Given this list of marker genes Tgfbr3 (NCBI Gene Id 73753), Fgf8, Ccn1, Mir18, Zbtb14, Lmo4, Dnah11, Bmp4, Nsd2, Dhrs3, Mir92-1, Zfpm2, Trip11, Notch1, Mir19b-1, Nphp3 (NCBI Gene Id 74025), Fzd1, Nos3, Pitx2, Cxcr4, Ift88, Chd7, Smad7, Hey1, Cited2, Tbx20, Mdm2, Mir20a, Kif7, Slit2, Pax8, Nfatc1, Parva, Nprl3, Sall4, Dand5, Heg1, Tbx2, Notch2, Hectd1, Matr3, Gata4, Msx2, Nog, Nrp1, Xirp2, Egln1, Rbm15, Wnt11, Mdm4, Smad6, Maml1, Pcsk5, Tgfbr2, Mir19a, Hand1, Dvl3, Tab1, Ap2b1, Wnt5a, Dnm2, Bmp7, Plxnd1, Cfc1, Kcnj8, Mir17, Sall1, Acvr1, Ank2 (ankyrin 2, brain), Vangl2, Bmp5 (bone morphogenetic protein 5), Fzd2, Prox1, Robo2, Aplnr, Tbx5, Nrp2, Sox11, Tbx3, Adamts19, Eng, Snx17, Robo1, Sox4, Id2, Stra6, Fgfr2, Mks1, Bmpr2, Lrp2, Lrp1, Gata3 (GATA binding protein 3), Bmpr1a, Sav1, Tgfbr1, Prdm1, Hey2, Fgfrl1, Gja5, Smad4, Lrp6, Ptk7, Cplane1, Slit3 (NCBI Gene Id 632373), Trp53, Frs2, Tbx1, Heyl, Fuz, Nkx2-5, Cntrl, Gata6, Hes1 (hes family bHLH transcription factor 1), Ltbp1, Sema3c, Ndst1, Isl1, Hoxa13, Zfpm1, Pde2a, Dctn5, Jag1, Adamts6, Smo, Luzp1, Tgfb2, Sufu (SUFU negative regulator of hedgehog signaling), Smarca4, Myh10, Rbpj, here is a description of the gene set: The progression of a cardiac septum over time, from its initial formation to the mature structure. Mouse Gene Set: GOBP_CARDIAC_SEPTUM_DEVELOPMENT studied in species Mus musculus